Given this list of marker genes UBB, CTNND1, UBA52, CDH1, SRC, CBLL1, CTNNB1, UBC, RPS27A, here is a description of the gene set: InlA-mediated entry of Listeria monocytogenes into host cells Human Gene Set: REACTOME_INLA_MEDIATED_ENTRY_OF_LISTERIA_MONOCYTOGENES_INTO_HOST_CELLS studied in species Homo sapiens